The following is a description of a gene set: Genes containing one or more binding sites for (BARHL1) in their promoter regions (TSS -1000,+100 bp) as identified by GTRD version 20.06 ChIP-seq harmonization. Human Gene Set: BARHL1_TARGET_GENES from publication Yevshin I, Sharipov R, Kolmykov S, Kondrakhin Y, Kolpakov F (PMID 30445619) studied in species Homo sapiens, and this is the list of marker genes: TBC1D19, TOMM40, MIR194-2HG, LINC01588, AFF1 (ALF transcription elongation factor 1), SETD3, UEVLD (UEV and lactate/malate dehyrogenase domains), RMDN1, MRPL55, ARAP1, FAU, GAN, HSDL2-AS1, OTUB1, DOLK, RPL39L, IRF2, POLDIP3, SPSB3, STMP1, LINC01023, PRPF6, TMEM116, MAPDA (N6-Methyl-AMP deaminase), SEPSECS, BAZ2B, SNHG8, USP38-DT, FADS1, NAGK, PPAN, NOP16, H2AX, PTPN11 (protein tyrosine phosphatase non-receptor type 11), C17orf49, TXN2, DNAJC7, ENDOV, PSAP, POLR1C, OSBPL8, TAF10, DENR, CRNKL1, CCNA2 (cyclin A2), IQCH-AS1, EEF1A1, GTF2H4, GTF3C2-AS2, RPUSD4, CAPS2, PHF7, ZNF774, PCOLCE-AS1, COX6A1, ZDHHC16, KLHL7-DT, MTIF3, PLAC8, PPHLN1, INTS14, EIF1, AIMP1, DVL2, MAN2A1, STX18, CLRN3, ZNF692, COMMD3, NAGA, SLC35B1, MET, ESYT1, TTLL5 (NCBI Gene Id 23093), MSH3, SNX30, PINX1-DT, LRP2BP, HERPUD2, STAT1, CCNB1, UQCR10, PCBP1-AS1, SOCS4, NUP205, KDM5A, CYB561D2, ZNRD2, RAD51 (RAD51 recombinase), NEMF, MZT2A, TMEM267, PNPLA6, PGBD4, TTPAL (NCBI Gene Id 79183), C2orf92, COX20, EHBP1L1, GOLM2, LARP7, MOCS2-DT, ENSG00000266088, TMOD3, BAP1, TTC32-DT, NCBP2AS2, TULP3 (NCBI Gene Id 7289), ZC3H3, HOXA-AS3, TMC5, ZSCAN5A-AS1, PELATON, ZSCAN5A, P3H2, BCL10-AS1 (NCBI Gene Id 647393), ATP8A1, COX10, FBF1, LINC01347, RNASEH1-DT, SAMTOR, ZNF654, RRP9, LINC01409, SNX11, LSM8, SPG21, MRM3, FAHD2A, FOXM1, HDGF, TRIM23, ESR2, ZFYVE26, SHC1, CDK13, GGA3, COL17A1, ZNF669, IQGAP2 (NCBI Gene Id 10788), ADAT1, ASB6, NFYC-AS1, CDK13-DT, DMTF1, SARS2, L3HYPDH, GANAB, SERPINB5, MIR375, ARID4A, RAVER1, PRR4, ZNF721, SNX8, CDCA5, BTN3A2 (NCBI Gene Id 11118), PDE4D, SPATS2 (spermatogenesis associated serine rich 2), TTC1, RPL35, MED7, TXNDC11, AP3M1, YEATS4, ZNF143-AS1, TRMT10A, RBM48, TLCD1, NEK8, SNX30-DT (SNX30 divergent transcript), RPGRIP1L, SNHG16, MFN1, NUCB2, TARS1, PSMF1, CD2BP2, IRAIN, RABGEF1, TMEM101, BTF3, LYRM7, CSNK1G1 (casein kinase 1 gamma 1), PMS2CL, SMNDC1, PMF1-BGLAP, PSD3, FAM161A, GUK1, GIRGL, NUBPL, ZNF143, CAGE1, GOT1 (NCBI Gene Id 2805), EID2, MGST1, SLC9A1, ENSG00000255647, ZMAT5 (NCBI Gene Id 55954), PCBP1, YJU2B, EEPD1, COX15, ABHD14B, RABGAP1L, SLC38A6, RASSF1-AS1, SRSF11, LMF2, NCBP1, LUC7L2, MIR5188, ANAPC2, ZNF394, CENPK, TTC41P, HRAS, APOLD1, USP36, C1D, ISY1-RAB43, TRABD2A, SEPSECS-AS1, MRPL44, IK, MAP4, DBF4, ROCK1, NUBP2, CUEDC2, LMBRD2, THNSL1, CHP1, WDR83, SEC11C, SFSWAP, HAUS5-DT, REG4, UBE2B, CRIPT, CDK5, FAM98B, PIK3C2A, MAGOH-DT, PIGU, EML4, TPR, CASP6, CYREN, CCDC51, PBRM1, TSPYL1, PAFAH1B2, TAF1D, RHEB, SMU1, ATRIP, SRSF1 (serine and arginine rich splicing factor 1), NOP9, TMEM128, MATCAP2, PRMT5-DT, GPAM, MIR4727, RASSF1, NRAS, EIF3J, CETN3 (centrin 3), ZNF250, ARHGAP32, POM121, C6orf120, HIBCH, COPS8-DT, BNIP3L, PROSER1, NUP42, RNASEH1, RPL29, GUF1, CNTRL, RPRD1B, GIN1, NABP2, DUT, PKM (NCBI Gene Id 8127), POLR2H, DDX24, NUP153, CNOT8, RPS27L, ZNF213, SF3B6, TP53RK, GOT1-DT, PLAA, MEPCE, RPS6KB2, DSTN, LINC01237, RPL34-DT, NFKB2, LYSET, INCENP, PRPF40B, COASY, MED27, GTF2IP13, EIF3J-DT, ZNF770, EGR1, PFKM, AGR2, ZNF460, ISY1, FDXR, TMCC3, EFHC1, FTO, NOC4L, WDR74, PSD, XPO1, PCBP4 (NCBI Gene Id 57060), DNAAF10, CLPX, ARMH4, SNX17, STX18-AS1, CSRNP2, PCCB, MYPOP, ODAD1, OSBPL1A, RFX2, FSIP1, SDR39U1, TRIM37, EME1, ORMDL3, DBI, GOLGA1, EIF2S2, CNOT1, DHFR, TICRR, RPLP0 (NCBI Gene Id 6175), CLNS1A, INO80E, HEMK1 (HemK methyltransferase family member 1), GATC, SCAF11, HIBADH (3-hydroxyisobutyrate dehydrogenase), LAPTM4A, NDUFV3, GTF2IP12, MBNL1, PRKG1-AS1, ADPGK, PIGO, PIGG, MAP3K5, CCDC86, ZSCAN2, HIGD2A, CPEB4, NUDT3, MZF1, ABHD14A-ACY1, CRAT (carnitine O-acetyltransferase), COPS8, POLG2, AK6, MIR4999, COA3, HM13, FKBP14, MLLT3, NFKBIZ, DGKA, ALDH1A2, ZNF252P, FBXL13, KLC4, RAD18, SLC35F5, JMJD6, SH3RF2, RUSC1 (RUN and SH3 domain containing 1), CGGBP1, SH3D19 (SH3 domain containing 19), ZNF44, USP53, LNPEP, STARD9, DNAJB12, HELLS, MAP4K1, PCDH1, PPIP5K2, TMEM144 (NCBI Gene Id 55314), EIF2A, NUBPL-DT, DHCR7, IRF2-DT, KIF15, MUL1, HBP1, SYPL1, CUL5, CERCAM, LRP6 (LDL receptor related protein 6), FXR1, RANBP2, PLK2, WDR5B-DT, VPS37A, NARS2, PKIB, RPS18, EIF2S1 (eukaryotic translation initiation factor 2 subunit alpha), RPPH1, RCCD1, TRAPPC13, CNTD1, MORN2, NHLRC3, MIR4734, SLC16A13, GZF1, SPPL3, MMAB (metabolism of cobalamin associated B), MRPS22, PIGO-AS1, COG2, PRDM1 (NCBI Gene Id 639), SEPTIN7P13, FANCD2, ZNF589, PPIC, PAXIP1, IFNAR1, CHMP4B, PNKD, GNL3 (NCBI Gene Id 26354), SPHK2, HPS4, NOD1, ARPC5L, PRORP, WDR27, ACTB, CRKL, TTC23, BRCA1, TMEM160, GTF2IP20, NBR2, MIB2, OTUD6B, COX5B, RPS7, SNHG1, ZBED3-AS1, RNU4-2, WDR6, SERP1, RAD17, RANGAP1, MIR762HG (MIR762 host gene), ZNF692-DT, HBS1L, SIPA1L1, MRPL2, SEPTIN7P2, NUP188, SNORD27, H2BC4, POLR3F, HDDC2, UQCC6, CYP2S1, FUT11, XRCC1 (NCBI Gene Id 7515), ETFA, RABIF, AP2A1, CHEK1, RPL6, ARFGAP2, ZNF561-AS1, JKAMP, DSE, TMEM9B-AS1, SAE1, MARCHF5, HECTD1, PRPF40A, SNORD25, MAML3, UBAP2, TRIM56 (NCBI Gene Id 81844), SLC33A1, USP14 (NCBI Gene Id 9097), EPRS1, DNMT1, TRIM52, ADK, GNL2, BLOC1S5-TXNDC5, KPTN, ZNRD2-DT, FTSJ1, CYB561D1, MTHFR, MROH8, JAK2, RHOF, RNU12, SLC38A9, IFT74, PRMT5, ZC3H10, H4C16, C5orf15, KIAA1958, CRB3, USO1, RPL7L1, ZNF576 (zinc finger protein 576), FBXL19, SEC22C, POLR2E, FAM76B (family with sequence similarity 76 member B), RPL34, ZNF252P-AS1, NIF3L1, SCAF1, ENSG00000224090, KIF18B-DT, MIF4GD, NCAPH2, COX7A2L, AREL1, TAF13, STAG3L5P-PVRIG2P-PILRB, LARP4, INKA1, ATP5F1A, FAAP100, YWHAH, SLC30A6-DT, ATP6V1D, LDHA (lactate dehydrogenase A), PWP1, MFSD14B, CREBL2, COG8, NPRL2 (NPR2 like, GATOR1 complex subunit), DMTF1-AS1, MTG2, TAX1BP1, TMEM52, CHRAC1, PCNX3 (pecanex 3), BDP1, SPRY4, DECR1, BECN1, ANKRD37, WASL, PRPF4, RNU5D-1, AAMP (NCBI Gene Id 14), NDUFA2, CENPL (centromere protein L), RHBG, GPN2, SAP30BP, ZKSCAN8, H2AC16, CMPK1, HIRIP3, POLR2K, GSK3A, CISH, AHCTF1 (NCBI Gene Id 442770), ENSG00000260830, EPHB4, NUTF2, NIPA2, ZNF687, RPS8, DCAF11, ZFAND2A-DT, LAPTM4A-DT, UQCC5, TSEN2, TRMT2A, BRPF1, MARCHF3, EIF3E, TCP1, INKA2, PTPRA, REX1BD, BLOC1S4, KIF18B, RAB11B, ACYP2, G3BP1, MON1A (NCBI Gene Id 84315), ZHX1, KDM3A, GEMIN5, TM9SF4, RPL24, PARP3, PSMC5, AP1G1, PIGT, CCDC7, IMP4, P3H2-AS1, NIP7, CLCN3, SRCAP, PTMA, MAP3K11, MTHFS, ZNF473, SOS1, TRMT5, NPHP1, TUFM, SGF29, LRRC40, HAUS2, IRF6, PPP2R3C, RPL12, DNAJC2, ATAD1, SNHG15, TTC9C, BRMS1 (NCBI Gene Id 25855), ANLN, VPS33A, TPK1, CREM (NCBI Gene Id 1390), DKK1, SLC25A1, ZNF23, ZHX1-C8orf76, SPG7, MRPS12, PDE7A-DT, EIF3K (NCBI Gene Id 55373), TOMM20, WWC1, TOB2, NDUFB2, HSPA9, ADAM15, ARHGEF37, METTL23, QTRT2, ARL6IP6, NTMT1, BORCS5, COPZ1, SEPTIN7P14, PMF1, MRPS7, BZW1, HMGN2P46, NAA40, MMUT, MLEC, MOSPD3, EIF2AK4, SRRM5, LMTK2, GLOD4, PARP2, ASNSD1, IDE, DNTTIP1, SNORD1C, MORN4, TMCC1, PPIH, PXN-AS1, ZNF384, ZNF181, SNHG17, RNF7, PLEKHA8, ZNF33B, NAPA-AS1, EBAG9, RRP15, YTHDF3, COQ7, C7orf50, ATAD3B, TAS2R14, EMC2, URB1-AS1, PSMD13, ASAH2B, DZANK1, TRIAP1, RIOK1, NIPBL, ITGA3, PHKG2, RCC1, RNF10, C15orf61, SCARB2, YTHDC1, RPL18, SPNS1, FHIT, WDCP, EIF4A1, POLG-DT, SH3BP5L, LRRC56, TADA1, CWC25, ST3GAL2, KIF3A, BRAF, APTX, RGS2, PPIL3 (peptidylprolyl isomerase like 3), TENT4A, SSBP1, PLS1, VTRNA1-2, NDUFS1, HACD3, BRD10 (bromodomain containing 10), PIKFYVE, KNTC1, GABPB1-AS1, PPP1R12B, FBXL18, SKA3, RFC1, LLGL2, UBE2V1, STARD10, DPY19L4, RAB11B-AS1, DHX40, MECR, C1orf105, RIMKLB, ATOSA, MRPL1, CFAP57, DDIT4, NOL11, ERCC5, H2AC15, ZNHIT3, TAF6L, CCNT2, RBM34, SNHG12, PINX1, ALOXE3, EXOSC1, FZR1, PSTK, FAM135A, SENP1, FAN1, IGF2BP2-AS1, EXOSC9, SLC50A1, USP54, ANXA2, SLC25A40, TAF9, NT5C3A, LOH12CR2, BCLAF1, TBL2, MOK, RASGEF1B, NFU1, DTX4, RNU5E-6P, ZFP62, RPS20, SNTB2, LRRC57, SPTLC1, PPIG, FAM118B, RHNO1, ESD, CNOT7 (NCBI Gene Id 29883), LARS2, FBXO16, EIF2D, ENKUR, CLEC16A, MIR4638, EXD1 (NCBI Gene Id 161829), TP53RK-DT, GRPEL2, ZFAS1, EBNA1BP2, MAN2A1-DT, VDAC3, STK11IP, AKT1S1, CDKN1B, ARL14EP, SNRPE, ZFHX2, TMEM69, CDC26, SHLD3, UMAD1, KDM1A, IGSF23, CERS6, THRAP3, DHCR7-DT, PEX1, VPS52, AHSA1, ZNF341-AS1, RPAP2, TNIP1, ATP8A1-DT, BBS9, CATSPERD, SKP2, MTMR9, CCT8, NEDD9, MAP3K8, SNHG5, IQGAP1 (IQ motif containing GTPase activating protein 1), NUP214, MIR3124, TMEM248 (NCBI Gene Id 55069), NFYC, CKS1B, AKAP3 (NCBI Gene Id 10566), TUBGCP6, CFDP1, SNHG3, PTPA, ZBTB4, TPD52L2, WDR4, RANBP1, ENSG00000232876, EIF3B, SNORA24, SSNA1, HMG20A, RN7SKP114, BLOC1S1, TMA7, MAGOH (NCBI Gene Id 4116), SLC9B1, LRP10, SLC27A5, ACAT2, THTPA, PSPH, WDR53, MSL2, DHX33-DT, LONP1, KIAA0319L, TMEM167B, MIR194-1, RBM47, MGRN1, DXO, COQ7-DT, KANSL1, RNF213-AS1, UBXN4, EIF1AY, YWHAE, CCT6A, CENPS, HSPA8P3, ENSG00000257184, SLC38A1, ZNF398, FBXO45, ARL4A, NCKAP5L, VPS28, PPOX, YIPF3, TFIP11-DT, KLHL12, HMGCR (3-hydroxy-3-methylglutaryl-CoA reductase), THUMPD1, LINC02851, BCAR3, LINC00938, MRPL4, METTL14-DT, DGLUCY, RNF216, USP20, CCDC163, MTRFR, CFAP410, ICE1, PRH1, RN7SL521P, IDI1, SRRD, THAP6, IBTK, LIN54, STARD3NL, E2F6, ZGRF1, ZNF212, MLH1, NCBP2, L3MBTL2, KIAA1143, UBE2D3-AS1, ADAR, ABCF2, RCHY1, LRSAM1, PSMB6, WWTR1-AS1, BRK1, PDE7A, PSMC2, RPS15A, RAD51-AS1, FTSJ3, ELAC2 (NCBI Gene Id 60528), BIN3 (bridging integrator 3), MAPKAPK3, TIAL1, CRELD1, DHX33, GDPGP1, EFCAB5, UBC, NT5C, VRK3, NANS, PPP2R3B, CENPQ, BRD2, NUP155, TBX3, RBM22, C9orf78, DIP2A, RLF, EIF2B4, ITGA7, TBC1D16, RPA3, MIR4258, PPP1R11, HAVCR2, LDB1, XPOT, MAGOHB, KCMF1, MED6, H2AC6, SLC35E3, STIM2, RPL31, COX10-DT, USP21, A2M-AS1, LTBP4 (latent transforming growth factor beta binding protein 4), RN7SKP175, ZBTB48, NCDN, ERP29, ZMAT2, PPP1R14B, SEH1L, ETS2-AS1, WEE2-AS1, DDX55, IFI27L1, CENPS-CORT, SCAND1, SDAD1, RABGAP1L-DT, KPNB1-DT, NEK1, GSAP, LMO7, TMED10, MVK, IFRD1, TRUB1, SELENOW, LYSMD3, GMPPB, EPM2AIP1, PCOLCE, CYB5D1, TMEM91, CYP4A22-AS1, DDX51, ARMC1, SDCBP2 (syndecan binding protein 2), PABIR1, OSBPL11, CAAP1, CDK11B, MRPL49, SLC24A1, RCE1, CA11, SNORD12C, ZCRB1, NDUFAF1 (NADH:ubiquinone oxidoreductase complex assembly factor 1), ZNF26 (NCBI Gene Id 7574), ARMC10, GTF2B, SPRY4-AS1, NAF1, CSNK1A1, SNORD26, PHAX, CYTH2, AIRIM, RRM1, SKIDA1, BLOC1S5, ABI2, SKOR1-AS1, ESRP2, ZNF200, LINC02427, CCDC78, ODR4, CEP83, ZNF689, ASIC1, USP38, HEXIM1, RPP14, CCNT2-AS1, CFAP61, RBM42, PUM3 (NCBI Gene Id 9933), KLHL7, CENPBD2P, FNBP4, PSME3, BOD1, IFRD2 (NCBI Gene Id 7866), MDN1 (midasin AAA ATPase 1), KLHDC10, G3BP2, CEP57, SNORA9, COQ5, POP4, EEF1B2, DLST, CFL1P1, SNORD55, SYK, FCF1, IRGQ, NFE2L2, MPHOSPH9, BCL10 (BCL10 immune signaling adaptor), WDHD1, PCIF1, USP35, TTI1, TRMT10C, SLC4A2 (NCBI Gene Id 96677), PPWD1, KHSRP, GCNT3, VIPAS39, TMEM9B, PARP4 (NCBI Gene Id 221181), MMACHC (metabolism of cobalamin associated C), CEP350, DRC3, SNORA16A, NAA38, CSRP2, DNAJB1, ORC2, BFSP1, CPEB3, MIR760, DFFA, TMCC1-DT, COX18, HSP90B1, MANCR, TNKS, WWTR1, ZFPL1, VPS4B, CDCA7L, BTF3-DT, PHB2, H2BC16P, NDC1, MTTP, DDX47, ZCWPW1, CCDC124, SDC1, BCAS3, IFT172, TASOR2, DMXL1, TBCK, ZCCHC8, POLR2A, RPL14, HAUS5, GABPB1, HOXA6, TSTD2, ZNF561, KPNB1, PTPRO, STYK1, CNOT9, KCTD7, CDK5RAP1, LRIG2, UBE2D3, LRFN4, EEF1E1, VARS2, ERP44, DDX46, ILF3-DT, GTPBP3, POLG, HMOX2 (NCBI Gene Id 3163), DHX57, ODAD3, PEAK1 (pseudopodium enriched atypical kinase 1), SLC3A2, PRKCSH, TFIP11, SERF2, SNORD28, ABCB8 (ATP binding cassette subfamily B member 8), PAFAH1B3, ATG4C, EEF1E1-BLOC1S5, H2BC15, RAB8B, HACL1, HTD2, STAG3L5P (STAG3 cohesin complex component like 5, pseudogene), NR2F2 (NCBI Gene Id 7026), ILF3, DYNLT1, CIDECP1, CORO2A, PON3, GTF3C2, NMRAL1 (NCBI Gene Id 57407), ZNFX1, CERNA3, SPATA7, ISCA1, RNF14, ZBED3, ZNF514, QTRT1, BUB1B, BCDIN3D-AS1, LRRC28, TOM1L2, ZNF460-AS1, RPIA, EMC7, EPS8, CCDC115, SNORD54, LTBP3, SEPHS2, MACC1, RPN2, MIA3, HAGHL, FADD, UIMC1, CNBD2, RACGAP1, PIK3R4, PPAN-P2RY11, POC5, RSL24D1, C2orf76, TRIM41, WDR83OS, ATG7, TARS1-DT, SIRT3, CDK11A, ZNF688, SUDS3, PFAS, TM2D1, RECQL5, CACTIN, PAFAH1B1, MRPL18, CLCN6, ZFAND2A, ZNF213-AS1, UBXN1, HNRNPUL2-BSCL2, B9D2, HNRNPUL2, RILP, PNO1, SNORD46, PCBP2, RPS29P16, MRPL36, CCDC191, NOLC1, INTS13, ELOB, ZNF2, WFDC3, SH2D7, ENSG00000272195, KCTD21, ZFAND1, PIERCE2, CDKL3, TUBGCP3, MIR4519, USP37, WDR5B, CCPG1, LINC02971, MRPL27, ASB16-AS1 (NCBI Gene Id 339201), ATP5MJ (NCBI Gene Id 9556), YTHDC2, WDR37, PSMA3-AS1, DYNLL1, METTL14, MBD1, CALM2, TBC1D17, APOA1-AS, YIPF7, RPS13, MRPL57, SRSF9, PIGC, SUPT3H, CCNK, STK40, ACP6, GRIPAP1, EMG1, C1orf21, TMUB2, GFER, ABT1, URB1, MALINC1, ERG28, SDAD1P1, ABHD2, FAM228B, CCNI, TOP1, DHRS1, STK19, SH2B1